The following is a description of a gene set: Human Gene Set: REACTOME_DNA_STRAND_ELONGATION species: Homo sapiens DNA strand elongation, and this is the list of marker genes: POLA2, RFC5, POLD2, PCNA, RFC1, PRIM2, LIG1, RFC3, CDC45, DNA2, RPA2, PRIM1 (DNA primase subunit 1), RPA1, GINS2, MCM4, MCM8, RFC2, MCM2, MCM6, GINS3, FEN1, POLD4, RPA3, MCM5, POLD3, GINS4, MCM3, MCM7, RFC4, POLA1, GINS1, POLD1